The following is a description of a gene set: Any process that stops, prevents or reduces the frequency, rate or extent of oxidative stress-induced neuron intrinsic apoptotic signaling pathway. studied in species Mus musculus Mouse Gene Set: GOBP_NEGATIVE_REGULATION_OF_OXIDATIVE_STRESS_INDUCED_NEURON_INTRINSIC_APOPTOTIC_SIGNALING_PATHWAY, and this is the list of marker genes: Atf4, Fzd1, Wnt1, Pycr1, Fgf2, Park7, Prkn, Il10, Ctnnb1 (catenin beta 1), Fbxo7, Pink1, Nono, Hif1a